Given this list of marker genes CARMIL2, CARMIL1, ACTN1, LCP1, PLS1, PLS3, COBL, SPIRE2, SPIRE1, here is a description of the gene set: Human Gene Set: GOBP_ACTIN_FILAMENT_NETWORK_FORMATION species: Homo sapiens The assembly of a network of actin filaments; actin filaments on different axes and with differing orientations are crosslinked together to form a mesh of filaments.